Given this list of marker genes DCN, CSPG5, VCAN, CSPG4, CHSY1, NCAN, BGN, BCAN, here is a description of the gene set: Chondroitin sulfate synthases (CHSY) are involved in the synthesis of chondroitin sulfate, adding alternatingly glucuronate (GlcA) and N-acetylgalactosamine (GalNAc) to the growing chondroitin polymer. Defects in CHSY1 cause temtamy preaxial brachydactyly syndrome (TPBS; MIM:605282), a syndrome characterized by multiple congenital anomalies, mental retardation, sensorineural deafness, growth retardation and bilateral symmetric digital anomalies mainly in the form of preaxial brachydactyly (literally, shortness of fingers and toes) and hyperphalangism. studied in species Homo sapiens Reactome Pathway: Defective CHSY1 causes TPBS part of: Diseases associated with glycosaminoglycan metabolism